The following is a description of a gene set: Human Gene Set: PID_FCER1_PATHWAY Fc-epsilon receptor I signaling in mast cells from publication Schaefer CF, Anthony K, Krupa S, Buchoff J, Day M, Hannay T, Buetow KH (PMID 18832364) species: Homo sapiens, and this is the list of marker genes: LYN, DOK1, PLPP1, AKT1, RASA1, VAV1, PAK2, DUSP1, NFATC2, WIPF1, ITK, CBLB, NFKB1, CBL, PLCG1, SPHK1, MAPK3 (mitogen-activated protein kinase 3), PIK3R1, GRB2, MAP3K1, PTPN11, FCGR2B, PTK2, PLA2G1B, RELA, S1PR1, LAT2, IKBKB, CHUK, GAB2, MAPK1, LAT, FER, FCER1A, RAF1, PLA2G4A, SYK, HCLS1, IGHE, FOS, MAP2K1, IKBKG, FYN, BTK, MAPK8, MAP2K2, SOS1, PIK3CA (NCBI Gene Id 5290), JUN, MS4A2, MAP2K7, HRAS, LCP2, SHC1, PXN, PLD2, MAP2K4, PTPN13 (protein tyrosine phosphatase non-receptor type 13), FCER1G, PRKCB